The following is a description of a gene set: Binding to a connexin, any of a group of related proteins that assemble to form gap junctions. Mouse Gene Set: GOMF_CONNEXIN_BINDING studied in species Mus musculus, and this is the list of marker genes: Cav3, Cxadr, Tjp1, Cnst, Gja5, Gja1, Src